Given this list of marker genes PLA2G2A, VEGFA, CRIPTO, FLT1, SRC, TGFBR2, FGR, SMAD2, PRNP, TGFB2, LYN, TGFB3, TGFB1, BLK, SERPINC1, YES1, NRG1, FGF2, HCK, FYN, GPC1, APP, FGFR1, LAMA1, TGFBR1, SLIT2, LCK, here is a description of the gene set: from publication Schaefer CF, Anthony K, Krupa S, Buchoff J, Day M, Hannay T, Buetow KH (PMID 18832364) species: Homo sapiens Glypican 1 network Human Gene Set: PID_GLYPICAN_1PATHWAY